Given this list of marker genes DAG1, POMGNT1, here is a description of the gene set: Reactome Pathway: Defective POMGNT1 causes MDDGA3, MDDGB3 and MDDGC3 part of: Diseases associated with O-glycosylation of proteins studied in species Homo sapiens Protein O-linked-mannose beta-1,2-N-acetylglucosaminyltransferase 1 (POMGNT1; CAZy family GT61; MIM:606822) mediates the transfer of N-acetylglucosaminyl (GlcNAc) residues to mannosylated proteins such as mannose-O-serine-dystroglycan (man-O-Ser-DAG1). DAG1 is a cell surface protein that plays an important role in the assembly of the extracellular matrix in muscle, brain, and peripheral nerves by linking the basal lamina to cytoskeletal proteins. Defects in POMGNT1 (MIM:606822) result in disrupted glycosylation of DAG1 and can cause severe congenital muscular dystrophy-dystroglycanopathies ranging from a severe type A3 (MDDGA3; MIM:253280), through a less severe type B3 (MDDGB3; MIM:613151) to a milder type C3 (MDDGC3; MIM:613157).